The following is a description of a gene set: A paroxysmal, transient loss of memory function with preservation of immediate recall and remote memory but with a severe impairment of memory for recent events and ability to retain new information. Transient global amnesia Human Gene Set: HP_TRANSIENT_GLOBAL_AMNESIA species: Homo sapiens, and this is the list of marker genes: HLA-DQB1, TRANK1, MOG, PDGFB, P2RY11, NF2, ZNF365, YY1, PIK3CA (NCBI Gene Id 5290), SMO, TERT, AKT1, SUFU, HLA-DRB1, TRAF7, TNFSF4, SMARCE1, CTSH, HCRT, MEN1, BAP1, SMARCB1